The following is a description of a gene set: Mouse Gene Set: GOBP_BLOOD_VESSEL_MORPHOGENESIS The process in which the anatomical structures of blood vessels are generated and organized. The blood vessel is the vasculature carrying blood. species: Mus musculus, and this is the list of marker genes: Igf2, Vegfc, Mcam, Lrp5, Spi1, Ednra, E2f2, Dysf, Epgn, Chi3l1, Foxo4, Or10j5, Ccn6, Rela, Fzd8, Uts2, Acvrl1, Smarca4, Cfh, Esm1, Lgals3, Hif3a, Sox18, Mir143, Nr4a1, Plxnd1, Atf2, Tbx20, Vav3, Ngfr, Sos1, Tgm2, Hspa12b, Gpr4, Ecscr, Jam3, Stab1, Mir27b, Nodal, Ace, Nppc, Mmrn2, Ccl5, Optc, Gna13, Cd36, Jup, Klf2, Adamts9, Comp, Eng, Shb, Cma1, Ackr3, Hoxa1, Clic3, Ccr3, Ppp1r16b, Cela1, Vegfb, Hgf, Xbp1, Grem1, Gadd45a, Aggf1, Pik3r2, Hey1, Zfpm2, Slc12a2, Pnpla6, Vangl2, Fgfr2, Ngp, Rnf213, Nras, Sirt1 (NCBI Gene Id 93759), Pdcd6, Ptprb, Bcam, Eya1, Ntrk2, E2f7, Asb4, Has2 (NCBI Gene Id 210441), Syk, Bax, Epo, Wasf2, Rnh1, Tnfsf12, Ptn, Gpld1, Zc3h12a, Cxcl10, Slc1a1, Tjp1, S1pr1, Nus1, Qki, Pitx2, Hmga2, Adgrb1, Myo1e (myosin IE), Fut1, Klf5 (NCBI Gene Id 75093), Flna (filamin, alpha), Sema3e, Mir329, Lama1, Egf, Agtr1b, Nrp1, Uts2r, Mecp2, Pik3c2a, Npr2, Ihh, Pxdn, Angptl4, Angptl3, Slit2, Naa15, Adgrb2, Rhoa, Scg2, Tgfa, Hdac7, Itga7, Dcn, Runx1, T, Yap1, Nkx2-5, Ninj1, Robo1, Mtdh (metadherin), Ptprj, Htatip2, Nedd4, Ramp2, Ctnnb1, Bmper (NCBI Gene Id 73230), Prrx1, Apela, Serpine1, Serpinf1, Ghsr, Prok2, Vezf1, Dll4, Prkd1, Cited2, Pik3r6 (phosphoinositide-3-kinase regulatory subunit 5), Col3a1, Dab2ip, Smoc2, Cysltr2, Tfap2b, Pde3b, Nrarp, Tbxa2r, Ppp1r15a, Hoxa5, Rbm15, Il18 (interleukin 18), Adam15 (NCBI Gene Id 11490), Parva, Epha1, Sema6a, Fbxw7, Hand1, Pten, Col4a3 (NCBI Gene Id 12828), Ets1, Pknox1, Tcf21, Lox, Srf, Myo18b, Anxa3, Zmiz1, Ubp1, Nos3, Rhob, Hdac9 (NCBI Gene Id 79221), Micall1, Gpr15, Prok1, Prkcb, Gm28729, Amotl1, Apob, Emilin2, Itgav, Prkx, Jag1, Pecam1, Cripto, Psg22, Bsg, Prkca (protein kinase C, alpha), Synj2bp, Pbrm1 (polybromo 1), Tnfrsf12a, Zfp36l1, Stard13, Ccbe1, Prox1, Ccn1, Anxa1, Gja5, Mir23b, Chrd, Gab1, Pik3cd, Naxe, Smad5, Stat3, Stat1, Gbx2, Vhl, Crhr2, Loxl2, Tmem201, Wars2, Rhoj, Fgf2, Ago1, Hoxa3, Egfl8, Pparg, Fgf9, Lef1, Ptgs2, Cspg4, Ehd4, Rspo3 (R-spondin 3), Nrxn3, Itgb2l, Itgb1, Tbx4, Anpep, Thy1, Pofut1, Epas1, Adam12, Pik3r3, Notch2, Dll1, Med1, Rbpj, Hoxa7, Rxra, Prl2c2, Pik3cb, Shh, Egr3, Mapk7, Lif, Amotl2, Ddah1, Itgb8, Pkd2, Lrp1, Wnt5a, Emilin1, Abcc8, Prdm1, Wars1, Hdac5, Dag1, Zfp354c, Sp1, Amot, Ptk2, Tgfb1, Tgfbr3, Fgfr1, Cd47, Thbs4 (NCBI Gene Id 21828), Arhgap22, Hs6st1, Mir145a, Fn1, Plg (NCBI Gene Id 18815), Akt3, Jak1, Vav2, Hyal1 (hyaluronoglucosaminidase 1), Cd93, Ccm2, Mir24-1, Cxcr2, Ptk2b, Ang4, Rgcc, Cldn5, Wnt11, Rasa1, C1galt1, Efna1, Lep, Stim1, Adra2b, Nrp2, Prkd2, Ppp3r1, Erap1, Adamts1, Sec1, Stra6, Nox1, Apln, Hspb6, Mydgf, E2f8, Meox2, Il12a, Tgfb2, Otulin, Sema5a, Ndp, Anxa2 (NCBI Gene Id 12306), Sirt6, Emc10, Plcd3, Ago2, Plau, Rock1 (Rho-associated coiled-coil containing protein kinase 1), Kdr, Hbegf, Pdgfra, Ecm1, Sox17, H2-M3, Ang5, Cdh2 (NCBI Gene Id 12558), Gdf2, Fgf10, Flt4, Plcg1, Rtl1, Ramp1, Yjefn3, Ccdc134, Epn2, Vegfa, Akt1, Vps4b, Rora, Fmnl3, Cd34, Add1, Adgrf4, Abl1, Fgf18, Tert, Gjc1, Btg1, Jmjd8, Rin2, Spry2, Cyp1b1, Emp2, Hoxa13, Fbln5, Ccl24, Sgcd, Mapk14, Hand2, Stk4, Ang6, Ntrk1, Col8a1, Fkbpl, Casp8, Meis1, Fzd4, Dsg2, Foxh1, Ptgis, Lemd3, Sfrp2, Arid2, Mmrn1, Kctd10, Angpt1, Ephb4, Il12b, Sulf1, Tspan12, Hpse, Junb, Calcrl, Krit1, Prrx2, Cd160, Serpinf2, Wnk1, Minar1, Cx3cr1, Ldlr, Hes1, Ptger4, Smad6, Fgf8, Tgfbr2, Sh2b3, Bcas3, Ccn2, Apoh, Grn, Jcad, Tnni3, Enpep, Apoe, Tnfrsf1a, Cd40, Hhex, Ywhaz, Foxn1 (forkhead box N1), Wnt7a, Jun, Prcp, Mia3, Ptpn6 (NCBI Gene Id 15170), Cdc42, Ccl2, Pgk1, Hk2, Sec24b, Emcn, Ahr, Fap, Epor, Adrb2, Smad1, Hoxb3, Itgb3, Pf4, Hmox1, Nrcam, Arhgap24, Rap1a, Tnfaip2, Atp2b4, Hmgb1, Ang, Adtrp, Meis3, Gata6, Smo, Tlr3, Srpx2, Pank2, C5ar1, Adgra2, Cnmd, Alox5, Kat6a, Tek, Elk3, Six1, Ephb2, Tal1, Egfl7, Fgf1, Mir27a, Unc5b, Cxcr3, Brpf1, Pik3ca, Aimp1, Ism1, Pdpk1, Vegfd, Notch4, Hc, Ndnf, Ephb3, Epn1, Tmem100, Bmpr2, Adm2, Ncl, Smad7, Clic4, Tcf4, Fgfbp1, Pdgfb, Shc1, Adgrf5, Map2k5, Ephb1, Lepr, Klf4, Wnt7b, Naglu, Lrg1, Eif2ak3, Xdh (xanthine dehydrogenase), Nog, Col4a2, Tgfbr1, Jmjd6, Vash2, Hipk2, Itgax, Hspg2, Agtr1a, Cdh5, Hhip, Rras, Cemip2, Tspan18, Hif1a, Adm, Foxc1, Card10, Fyn, Plk2, Brca1, Col8a2, Efemp2, Hrg, Mdk, Flvcr2 (NCBI Gene Id 217721), F3, Chd7, Sgpl1, Ccn3, Prl7d1, Pkm, Mrtfb, Nr2f2, Robo4, Bmp4, Ctnnd1, Hgs, Cybb, Aqp1, Edn2, Adgrb3, Ereg, C3, Gtf2i, Vash1, Map3k3, Itga5, Foxj2 (forkhead box J2), Flt1, Map3k7, B4galt1, Tead2, Ccr2, Ptprm, Fzd5, Cul7, Pacsin2, Foxf1, Pik3cg, Sphk1, Clec14a, Vstm4, Mmp9, Pgf (NCBI Gene Id 18654), Ovol2, Bak1, Egln1, Il17f, Etv2, Itgb1bp1, Thbs2, Cx3cl1, Mmp2, Nfatc3, Gja1, Glul, Rasip1, Nprl3, Edn1, Creb3l1, Camp (NCBI Gene Id 12796), Nrxn1, Adipor2, Nr2e1, Mir23a, Tmem215, Tbx2, Slc39a12, Pdgfa, Wt1, Atp5f1b, Acvr1, Heg1, Dicer1, Gata4, Ctsh, Tbx1, Notch1, Itgb2, Plcd1, Sp100, Fgf6, Tnmd, Minar2, Gata2, Mir24-2, Aplnr, Cxcl12, Actg1, Pxn (paxillin), Mir126b, Bmpr1a, Pdcl3, Cib1, Hoxb13, Sema4a, Megf8, Tie1, Reck, Thsd7a, Wnt4, Tiparp, Pdcd10, S2bpcox16, Tgfbi, Nfe2l2, Fasl, Foxc2, Mmp19, Adgrg1 (adhesion G protein-coupled receptor G1), Rapgef3, Cav1, Il1a, Notch3, Tnf, Id1, Ceacam1, Zfp950, Mylk, Npr3, Paxip1, Glmn, Sox4, Mmp14, Spred1, Cited1, Enpp1, Ccl11, Sash1, Sparc, Folr1, Myocd, Efna3, Slc31a1, Cdh13, Rapgef2, Myh9, Setd2, Nfatc4, Hey2, Rock2, Nf1, Angpt2, Angpt4, Fkbp10, S100a1, Gpx1, Epha2, Thbs1, Col4a1, Angptl6 (angiopoietin-like 6), Hspb1, Srpk2, Col18a1 (NCBI Gene Id 12822), Il1b, Isl1, Sars1, Rtn4, Il10, C3ar1, Ccl12, Pdgfrb, Cd59a, Mfge8, Tnn, Cxcr4, Cysltr1, Pml, Adam8, Hpgd, Apold1, Itga2b, Foxm1, Becn1, Agt, Cxcl17, Ang2, Ghrl, Efnb2, Tafa5, Lrp2, Pak4